The following is a description of a gene set: Abnormal hallux morphology Human Gene Set: HP_ABNORMAL_HALLUX_MORPHOLOGY studied in species Homo sapiens This term applies for all abnormalities of the big toe, also called hallux., and this is the list of marker genes: TCF12, NBAS, FGFR2, GTF2I, FLI1, HOXD13, AKT1, SALL4, LETM1, GATA6 (NCBI Gene Id 2627), RFC2, HNRNPR, GJA5, BMPR1B, FGF9, HOXA13, CCDC22, TTI2, PRKAR1A, WDPCP, TBR1, SOX9, FHL1 (four and a half LIM domains 1), RHOA, METTL27, NPR2, ZNF469, SOX5, TWIST1, IMPDH2, KCNN3, PYCR2, FLNA, SMARCA2, TNNT3, FGFR1, FGFR3, IFT122, ROBO1, PTRH2, MED12, KCNJ8, TBX1, MLXIPL, CDK10, ADNP, CLIP2, GJA8, MFN2, SLC29A3, MYH3, SLC16A2, SF3B4, FGFRL1, NKX3-2, ELN, KMT2A, NCF1, CTCF, KMT2D, ABCC9, TPR, KCNH1, SMS, BUD23, PTH1R, VAC14, EBP, GBA1, HSPB8, NPR3, GCH1, PCDHGC4, GJA1, CWC27, NKX2-5, DNAJC30, MGP, LIMK1, ZFX, DNM1L, ALDH6A1, CSNK2A1, KAT6B, FKBP6, MEGF8, MEIS2, HYLS1, SMO, ZNF668, NXN, ZSWIM6, FAM20C, B3GAT3, YY1, KMT2B, TP63, FIBP, NELFA, ROR2, BCOR, PUF60, EIF4A3, NEK1, H4C9, NAA10, NUP107, ZEB2, NR4A2, RAB34, CTBP1, SALL1, ACTB, PIGO, ERMARD, EIF4H, SMC1A, ATP6V1B2, ASPH, PRDM5, COL2A1, AEBP1, PYCR1, DPM1, SIAH1, COL1A1, B3GALT6, MAP3K20, PPP2R1A, KIF7, CHSY1, NKX2-6, GNE, PIGG, NIPBL, ERF, USP9X, IFT172, DLX5, C2CD3, POLR3GL, UBE2A, SCNM1, USP7 (ubiquitin specific peptidase 7), KAT6A, SCAF4, HEATR3, IHH, FIG4, CREBBP, SATB2, GNPNAT1, PSMB8, CHST11, ACAN, CDKL5, DACT1, ACVR1, EHMT1, BPTF, PITX1, RBBP8, GTF2IRD2, EP300 (E1A binding protein p300), GLI3, BHLHA9 (basic helix-loop-helix family member a9), HSPB1, SRY, CPLANE1, ITCH, RAB23, CANT1, SCARF2, SPTAN1, DVL1, TMEM270, TAF6, GNAI1, LMBR1, LRP4, PDE4D, TBC1D2B, ZMIZ1, COL1A2, EFNB1, TBL2, NFIX, LBR, NSD2, STX1A, BMP2, ATL3, IL11RA, NONO, SETBP1, GDF5, NOG, TRPM3, TRAF7, DYRK1A, UBAP2L, CHST3, GATA4, GPC4, GTF2IRD1, VPS37D, KDM5A, CPLX1, PTHLH, BAZ1B, SUMF1, KIAA0753